The following is a description of a gene set: Human Gene Set: HP_HYPOMETRIC_SACCADES Hypometric saccades Saccadic undershoot, i.e., a saccadic eye movement that has less than the magnitude that would be required to gain fixation of the object. species: Homo sapiens, and this is the list of marker genes: DNAJC6, SLC1A3, SPTBN2, COQ5, NKX6-2, MAPT, APTX (aprataxin), TSPOAP1, TUBB4A, CACNA1G, MRE11, MYORG, PLA2G6 (NCBI Gene Id 8398), GRM1, NPHP1, MME, GBA1, ITPR1